The following is a description of a gene set: Genes encoding structural components of basement membranes from publication Naba A, Clauser KR, Hoersch S, Liu H, Carr SA, Hynes RO (PMID 22159717) species: Homo sapiens One hallmark of ECM proteins is their domain-based structure. Exploiting this characteristic, we established a list of diagnostic InterPro domains commonly found in ECM proteins. We know that some of the domains used to select positively for ECM proteins are also found in transmembrane receptors and proteins involved in cell adhesion (growth factor receptors, integrins, etc) that do not belong to the ECM. These families of proteins also display a subset of specific domains and transmembrane domains incompatible with definition as “extracellular matrix” proteins. Therefore, a second step comprised a negative selection using another set of domains and a transmembrane domain prediction. Manual curation of the matrisome lists also allowed us to add a very few known ECM proteins that do not contain any known domains. Protein-centric predictions were then converted to gene-centric lists. Finally, knowledge-based annotation of these gene lists allowed us to define subcategories within the core matrisome; namely, ECM glycoproteins, collagens, and proteoglycans. We also defined separate lists of domains commonly found in 1) ECM-affiliated proteins (proteins that share either some architectural similarities with ECM proteins or that are known to be associated with ECM proteins; 2) ECM regulators: ECM-remodeling enzymes, crosslinkers, proteases, regulators etc.; 3) secreted factors, many of which are known to bind to ECM and others that may. As for the core matrisome list, we also defined lists of domains that excluded mis-assigned proteins from these categories. Using similar bioinformatic pipelines as for the core matrisome, we defined three categories of “matrisome-associated” proteins: ECM-affiliated proteins, ECM regulators, and secreted factors. Human Gene Set: NABA_BASEMENT_MEMBRANES, and this is the list of marker genes: COL4A1, AGRN, COLQ, LAMA1, NID2, LAMB4, LAMA5, COL6A1, NTN4, HMCN1, LAMC3, LAMA2, NTN3, LAMC1, NTN5, LAMB1, PAPLN, LAMB2, LAMA4, NID1, COL6A5, COL6A6, LAMC2, NTN1, LAMA3, COL4A5, COL18A1, COL6A2, COL15A1, COL4A4, COL4A3, COL6A3, LAMB3, COL4A2, NPNT, NTNG2, USH2A, COL4A6, NTNG1, HSPG2